The following is a description of a gene set: from publication Chen Y, Wang X (PMID 31504780) species: Homo sapiens Human Gene Set: MIR4790_5P Genes predicted to be targets of miRBase v22 microRNA hsa-miR-4790-5p in miRDB v6.0 with MirTarget v4 prediction scores > 80 (high confidence targets)., and this is the list of marker genes: VCP, DENND1B, LRRN3, BANK1, ULK1, SMPDL3A, TMEM97, NCOR2, CCDC198 (coiled-coil domain containing 198), PSMG3, CBLIF, ZNF430, ELAVL3, RAB3A (RAB3A, member RAS oncogene family), FMR1, BEGAIN